Given this list of marker genes DNMT3B, LMX1B, CAPN3, FRG1, DUX4, SMCHD1, SALL4, DUX4L1, here is a description of the gene set: Human Gene Set: HP_ABNORMALITY_OF_THE_MUSCULATURE_OF_THE_THORAX Abnormality of the musculature of the thorax species: Homo sapiens A disease or lesion affecting the muscles of the thorax.